The following is a description of a gene set: species: Homo sapiens The human gene SLC34A2 encodes NaPi-2b which is abundantly expressed in lung and to a lesser degree in epithelia of other tissues including small intestine, pancreas, prostate, and kidney. In the lung, SLC34A2 is expressed only in alveolar type II cells, which are responsible for surfactant production, so it is proposed that it uptakes liberated phosphate from the alveolar fluid for surfactant production. SLC34A2 cotransports divalent phosphate (HPO4(2-)) with three Na+ ions (electrogenic transport) from the extracellular region into alveolar type II cells. Defects in SLC34A2 can cause pulmonary alveolar microlithiasis (PALM; MIM:265100), a rare disease characterised by the deposition of calcium phosphate microliths (tiny, roundish corpuscles) throughout the lung. Most patients remain asymptomatic for years or decades, the disease following a long-term, progressive course resulting in slow deterioration of lung functions. PALM can result in a potentially lethal disease. Reactome Pathway: Defective SLC34A2 causes PALM part of: Diseases associated with surfactant metabolism, and this is the list of marker genes: SLC34A2 (NCBI Gene Id 153010)